The following is a description of a gene set: from publication Chen Y, Wang X (PMID 31504780) species: Mus musculus Mouse Gene Set: MIR_32_5P Genes predicted to be targets of miRBase v22 microRNA mmu_miR_32_5p in miRDB v6.0 with MirTarget v4 prediction scores > 80 (high confidence targets)., and this is the list of marker genes: Hnf1b, Pik3r3, Cd69, Usp28, Tbl1xr1, Cic, Adam19, Atxn1, Herc2, Snx13 (sorting nexin 13), Gsta5, Ppcs, Exoc5, Tbc1d12, Pik3cb, Tagap, Evi5, Pten, Arrdc3, Bcat2, Grp, Bahcc1, Tmem87a, Zfp521, Dennd4b, Plekha1, Gm5148, Snap29, Nsd3, Tmem229a, Ptger4, Sik1, Bltp1, Gnpda2, Atp7a, Rhpn2, Appl1, D16Ertd472e, Myt1l, Tsc1, Tef, Dock9, Itgav, Adamtsl3, Fnbp4, Adcy3, Pank3, Tent4a, P3h3, Sox11, Nol4l, Avl9, Rab3c, Dusp10, Pik3ca, Gnaq, Phlpp2, Rsbn1, Gata2, Nek1, Robo1, Pcolce2, Ankrd44, Braf, Cadm2, Paxbp1, Plekhm1, Pla2g10, Golga7, Spryd4, Mfhas1, Tulp4, Klf4, Slx4, G3bp2, Col27a1, Dynlt3, Ezh2, Aggf1, Rab9b, Cdk16, Ptpro, Asxl2, Ranbp9, Ubash3b, Dkk3, Wwp2 (WW domain containing E3 ubiquitin protein ligase 2), Rad21, Cpeb2, Gpr158, Fkbp1a, Slc24a3, Nckap5, Ewsr1, Fosl2, B3galt2, Abhd13, Pdzd2, Akap10, Rab23, Trim65, Pitpna, Rfx1, Bsdc1, Btg2, Rab8b, Tbx20, Zfp287, Prkar2b, Zim1, Herpud2, Robo2, Adam10, Scn8a, Nfyc, Grip2, Nsmf, Hecw1, Dnajb9, Sgk3, Cpeb3, Rbpms2, Fbn1, Slc25a32, Xrn1, Pp2d1, Elk4, Atxn3, Klhdc10, Kifap3, Morc3, Peak1, Kat2b, Fcho2, Chia1, Ikzf2, Tgif1, Arf1 (NCBI Gene Id 11840), Klf2, Ddx3x (DEAD box helicase 3, X-linked), Sort1, Mapk8, Gla, Galnt14, Pip5k1c, Lats2, Mylip, Kcnd2, Snn, Bcl11a, Ric1, Dkk2, Rbm27, Trak2, Otud4, Gata6, Gpr180, Rgs3, Chmp7, Atrx, Ldlrad4, Zeb2, Bcl11b, Fzd10 (NCBI Gene Id 93897), Dtx2, Jmy, Lhfpl2, Xylt2, Gdf11, Cyp2d22, Mia3, Flvcr2, Ube2z, Pcgf3, Cux1, Cpeb4, Sgpp1, Greb1l, Pcdh9, Sfxn1, Pitpnm2, Gpc6, Stau1, Sertad3, Sim2, Ptar1, Trim36, Nsmaf, Ankrd28, Col1a2, Cep41, Hand2, Nufip2, Tmem184b, Gfpt2, Ube2w, Nox4, Tob2, Rev3l, Klhl14, Luzp1, Slco6c1, Srpra, Rbpj, Fry, Ddx3y (DEAD box helicase 3, Y-linked), Hcn2, Ugp2, Polk, Hps6, A830018L16Rik, Kcna1, Ssbp2, Prrc2b, Isca1, Adamtsl1, Fhl2, Dus2, Cog3, Snapc1, Nlgn1, Usp36, Stk39, Pcdh11x, Fbxw7, Myo1b, Iqgap2, Fmn2, Fam20c, Daam1, Zfp827, Zfp512b, Per2, Trio, Ttc9, Golga1, Phtf2, Tob1, Dcaf6, Map2k4, Slc6a1, P2ry13, Nol7, Tead1, Pcdh7, Kcna2 (potassium voltage-gated channel, shaker-related subfamily, member 2), Ptprk, Lmbr1l, Map1b, Cnep1r1, Synj1, Dpp10 (NCBI Gene Id 269109), Glyr1, Ccnjl, Ago3, Gsta2 (glutathione S-transferase, alpha 2 (Yc2)), Mboat2, Arrdc4, Baz2b, Itga6, Tcf21, Stx17 (syntaxin 17), Cdca7l, Glce, Rassf3, Rnf4, Pnisr (NCBI Gene Id 66625), Arid1b, Ergic2, Ibtk, Mast4, Csmd3, Adam23, Wrnip1, Rgs17, Hivep1, Prkar1a, Dsc2, Insig1, 1810055G02Rik, Med19, Osbpl8, Fnip1 (NCBI Gene Id 216742), Zfc3h1, Pcmtd1, Hipk3, Cldn11, Mpp1, Ddc, Abcg4, Lpin1, Tpcn1, Rpl15, Sh3pxd2a, Rora (RAR-related orphan receptor alpha), Notch1, Nefm, Grhl1, Fli1, Itprid2, Syn2, Fhip2a, Rnf38, Gid4, Evx2, Acrv1, Wdfy3, Mycbp2, Itpr1, Jarid2 (NCBI Gene Id 97879), Nr1d2, Glra1, Bcl2l11, Dmxl1, Pkdcc (protein kinase domain containing, cytoplasmic), Golga4, Slc12a5, Bmpr2, Man2a1, Slc38a2, Dnaaf9, Fnip2, Cacna1h, Gramd2b, Armc1, Ptprj, Ppp1r12c, Ppp1r37, Nova1, Itga5 (NCBI Gene Id 16402), Klhl29, Aida, Slc25a36, Ccnc, Strn3, Itga8, Zfyve21, Dennd1b, Kmt5b, Edem1, Wasl, Foxn2, Fancm, Slc17a6, Npc1, Fmr1, Zdhhc5, Eomes, Myo5a, B230219D22Rik, Tafa1